Given this list of marker genes BMP5, CYP11B2, CLCN2, REST, CACNA1H, CYP11B1, WNT4, H6PD, DGKQ, BMP6, DAB2, PARK7, DKK3, BMP2, here is a description of the gene set: The chemical reactions and pathways resulting in the formation of primary alcohols. A primary alcohol is any alcohol in which a hydroxy group, -OH, is attached to a saturated carbon atom which has either three hydrogen atoms attached to it or only one other carbon atom and two hydrogen atoms attached to it. Human Gene Set: GOBP_PRIMARY_ALCOHOL_BIOSYNTHETIC_PROCESS studied in species Homo sapiens